The following is a description of a gene set: The process whose specific outcome is the progression of the ureter over time, from its formation to the mature structure. The ureter is a muscular tube that transports urine from the kidney to the urinary bladder or from the Malpighian tubule to the hindgut. Mouse Gene Set: GOBP_URETER_DEVELOPMENT species: Mus musculus, and this is the list of marker genes: Bmp4 (bone morphogenetic protein 4, NCBI Gene Id 12159), Foxf1, Sox17, Pax2, Emx2, Tshz3 (NCBI Gene Id 338507), Sox8, Shh, Gata3, Aldh1a2, Osr1, Sox9, Nphp3, Mecom, Lhx1, Nfia, Six1, Ret, Lzts2, Tbx18